Given this list of marker genes FGA, IGFBP7, COL14A1, FGG, VWF, VTN, F2, TNC, FGB (fibrinogen beta chain), FN1, COL6A4P1, ECM1, PLG, COL6A5, here is a description of the gene set: from publication Hebert JD, Myers SA, Naba A, Abbruzzese G, Lamar JM, Carr SA, Hynes RO (PMID 32019869) Human Gene Set: HEBERT_MATRISOME_TNBC_LIVER_METASTASIS Matrisome proteins found in significantly higher abundance in TNBC liver metastasis niche compared to TNBC brain, lung and bone metastatic niches. We have previously developed methods for enriching tissue samples for their ECM protein content by taking advantage of the relative insolubility of the ECM, and we have used these techniques in conjunction with mass spectrometry-based proteomics to profile the matrisome, the complete collection of both core ECM and ECM-associated proteins, in several different cancers. Here we define and compare the ECM components of metastatic niches and how they differ among the specific secondary sites common in TNBC. For this purpose, we use as a model the MDA-MB-231 human TNBC cell line, originally derived from a patient pleural effusion (24), which is capable of metastasizing to the brain, lungs, liver and bone marrow in mouse xenografts. We identify which ECM proteins are commonly elevated at multiple different metastatic sites, and which are preferentially elevated in particular sites. We investigate how these specific ECM proteins, as well as the tumor matrix overall, are differentially produced by the tumor and stromal cells; in this paper, we use stromal to include all cells in the tumor that are not tumor cells. These comparisons did not simply identify the most elevated proteins in each tissue, but rather the proteins most significantly different in abundance in one tissue relative to all others. Separate analyses were conducted for tumor-cell-derived (human) and stroma-derived (mouse) proteins. In this study, we performed an unbiased, quantitative mass spectrometric survey of ECM proteins present in MDA-MB-231 breast cancer xenograft metastases to the brain, lungs, liver and bone marrow. This gene set lists the matrisome proteins found in significantly higher abundance in TNBC liver metastasis niche compared to TNBC brain, lung and bone metastatic niches. species: Homo sapiens